Given this list of marker genes Syk, Dlc1, Camk2b, Pla2r1, Fyn (NCBI Gene Id 14360), Stxbp1, Lck, Apoc2l, Arhgap6, Srsf3, Lmnb1, Btk, Bank1, Src, Snca, Dgkq, Tgm2, Blnk, Ptpn11, Kat5, Prkcz, Apoc2, Nefl, Tespa1, Prkn (parkin RBR E3 ubiquitin protein ligase), Sele, Was, Pdpk1, Met, Snap91, here is a description of the gene set: Mouse Gene Set: GOMF_PHOSPHOLIPASE_BINDING species: Mus musculus Binding to a phospholipase.